Given this list of marker genes Hnrnpc, Parn, Cct8, Terc, Nhp2, Pkib, Mapk1, Hsp90ab1, Prkcq, Atr, Nat10, Ptges3, Tep1, Pif1, Trp53, Acd, Pml, Wnt3a, Gch1, Rad50, Tent4b, Terf1, Mapk15, Nek7, Pot1a, Exosc10, Mapkapk5, Nop10, Cct3, Fbxo4, Gnl3l, Atm, Terf2, Tnks, Pinx1, Pnkp, Dkc1, Gar1, Cct7, Pot1b, Cct5, Hsp90aa1, Cct4, Tert, Hmbox1 (NCBI Gene Id 219150), Nek2, Mapk3, Ptges3-ps, Parp4, Ctnnb1, Map2k7, Tinf2, Ten1, Cct6a, Aurkb, Ctc1, Hnrnpu, Tcp1, Rpa1, Stn1, Xrcc5, Map3k4, Cct2, Dcp2, Hnrnpd, Src, Wrap53, here is a description of the gene set: A DNA biosynthetic process that uses RNA as a template for RNA-dependent DNA polymerases (e.g. reverse transcriptase) that synthesize the new strand. Mouse Gene Set: GOBP_RNA_TEMPLATED_DNA_BIOSYNTHETIC_PROCESS studied in species Mus musculus